The following is a description of a gene set: Biventricular hypertrophy Thickening of the heart walls in both ventricles. species: Homo sapiens Human Gene Set: HP_BIVENTRICULAR_HYPERTROPHY, and this is the list of marker genes: POLR1A, TALDO1, DEPDC5, NDUFA11, DEF6, ATP6V1E1, MYRF, ALG12, MYH7, TNNC1, MYL2, PRKAG2, CACNA1D